The following is a description of a gene set: from publication Lund R, Aittokallio T, Nevalainen O, Lahesmaa R (PMID 14607935) species: Homo sapiens Th1 and Th2 cells arise from a common precursor cell in response to triggering through the TCR and cytokine receptors for IL-12 or IL-4. This leads to activation of complex signaling pathways, which are not known in detail. Disturbances in the balance between type 1 and type 2 responses can lead to certain immune-mediated diseases. Thus, it is important to understand how Th1 and Th2 cells are generated. To clarify the mechanisms as to how IL-12 and IL-4 induce Th1 and Th2 differentiation and how TGF-beta can inhibit this process, we have used oligonucleotide arrays to examine the early polarization of Th1 and Th2 cells in the presence and absence of TGF-beta after 0, 2, 6 and 48 hours of polarization. Genes up-regulated in CD4 T cells: untreated (0h) versus activated by anti-CD3 and anti-CD28 and then stimulated by TGFB1 and IL4 (6h). Human Gene Set: GSE2770_UNTREATED_VS_TGFB_AND_IL4_TREATED_ACT_CD4_TCELL_4H_UP, and this is the list of marker genes: TNRC6B, CNRIP1, FAM120B, RPL41, SAMD9L, IL6R, DUSP11, ULK2, DNAJC28, APBB3, KRTCAP3, PIGX, FOXO4, IER2, IPCEF1, ZPBP, SCAMP2, WBP1L, PDLIM5 (NCBI Gene Id 10611), LSP1, TPPP, AKT1S1, C15orf61, FAM120AOS, DNM3, PROCR, BAZ2A, ATXN7L3, PINK1, BCL2A1, GBP7, TMED8, IFNAR1, GNG10, SNAP29, HECA, MAP4K3, REEP5, CTSZ, ACAA1, ERO1A, TBC1D17, BCL9, RELCH, PDCD4, RAB31, TAX1BP1, SLC35D2, POU6F1, RELL2, CD36, MNT, TMEM127, IFI27L2, ACP5, TLR7, DYRK2, FAM8A1, DRAM2, CD47, S1PR4, IP6K1, UGCG, PSD3, AVL9, ARHGEF10, IL1RAP, CAPN7, PXDC1, RIMOC1, TMEM167B, RRAGC, KLF13, JTB, IRF2BP2, GPR108, RNFT1, AHCYL2, TBC1D23, SETD4, TRIM11, NDFIP1, COQ10B, DCXR (NCBI Gene Id 51181), HIPK2, MPP1, FBXL3, POU5F2, LGMN, PBXIP1, XAF1, PIP4P2, URM1, TRIM34, ANKRD44, NFKBIE, RPS11 (ribosomal protein S11), SLC35F6, UNC119B (NCBI Gene Id 84747), SEC63, CNR2, SLC4A10, ROGDI, MLLT6, TMED3, AKT3, USP12, ARID4B, JUNB, GIMAP1, NRBP1, STX5, INSR, ETV6, UVSSA, NSA2 (NSA2 ribosome biogenesis factor), PXN, SDC1, RCN3, KCTD6, ATRNL1, IGBP1, ZNF703, RSAD2, FNBP4, PAXBP1, SLC11A2, TENM4, RBM5, GABARAP, PAXX, SURF2, CDS2 (NCBI Gene Id 96708), COMTD1, C14orf28, ACAP2, BTK, RNF44, RAPGEF6, VAMP8, CYTH1, KLHL15, RECK, EPHX1, CREBZF, TNFRSF1B, CLCN5, SLC35C2, KIF9, DNAJC5, GLMP, N4BP2L1, PRKAB2, PPCDC, AVPI1, ARMC3, ZYG11B, CKB, FGL2, TRIAP1, EVA1B, PIK3R4, KLF7, ZNF524, SOCS3, NCF4, NUDT17, AP1M2, MAP1LC3B, ARV1, RIPOR1, TMEM202, CCR5, MED13, C1orf216, PTGER1, SMIM13, MYNN, SLAMF6, PLEC, BAZ2B, FBXO9, MPDU1, SLC6A13, AZI2, LY86, COQ8A, SRI, FLAD1, TMEM51, DNAH17, TMEM234, PDLIM2, CD84, MDP1, TRIM24, TEX264, CALCRL, SHARPIN, SUSD1